Given this list of marker genes IRAK4, DOCK8, CARD9, EGFR, CARD11, GPC4, CARD10, SPINK5, IL21, FASLG, IKBKG, PGM3, GPC3, NSMCE3, TYK2, WAS, IL6ST, COL7A1, CDSN, ZNF341, NFKBIA, POLD3, EXTL3, ADA, FOXP3, KRT9, DOCK11, CASP10, ADAM17, SLC19A1, STAT3, ARPC5, TGFB1, IL7R, DSG1, IPO8, DCLRE1C, IL6R, IL2RA, STAT5B, STAT6, NCKAP1L, CD247, FAS, KRT74, here is a description of the gene set: Increased circulating IgE concentration studied in species Homo sapiens Human Gene Set: HP_INCREASED_CIRCULATING_IGE_CONCENTRATION An abnormally increased overall level of immunoglobulin E in blood.